The following is a description of a gene set: Human Gene Set: GOBP_CELLULAR_RESPONSE_TO_MANGANESE_ION studied in species Homo sapiens Any process that results in a change in state or activity of a cell (in terms of movement, secretion, enzyme production, gene expression, etc.) as a result of a manganese ion stimulus., and this is the list of marker genes: EIF2AK3, LRRK2, SLFN14, PRKN, APP, ATF4, ATP13A2, EIF2S1, HSP90B1, BACE1